The following is a description of a gene set: species: Mus musculus Chemical induction of squamous tumors in the mouse skin induces multiple benign papillomas: high-frequency terminally benign low-risk papillomas and low-frequency high-risk papillomas, the putative precursor lesions to squamous cell carcinoma (SCC). We have compared the gene expression profile of twenty different early low- and high-risk papillomas with normal skin and SCC. Unsupervised clustering of 514 differentially expressed genes (P<0.001) showed that 9/10 high-risk papillomas clustered with SCC, while 1/10 clustered with low-risk papillomas, and this correlated with keratin markers of tumor progression. Prediction analysis for microarrays (PAM) identified genes that distinguished the two papilloma classes, and a majority of these had a similar expression pattern in both high-risk papillomas and SCC. Additional classifier algorithms generated a gene list that correctly classified unknown benign tumors as low- or high-risk concordant with promotion protocol and keratin profiling. Reduced expression of immune function genes characterized the high-risk papillomas and SCC. Immunohistochemistry confirmed reduced T-cell number in high-risk papillomas, suggesting that reduced adaptive immunity defines papillomas that progress to SCC. These results demonstrate that murine premalignant lesions can be segregated into subgroups by gene expression patterns that correlate with risk for malignant conversion, and suggest a paradigm for generating diagnostic biomarkers for human premalignant lesions with unknown individual risk for malignant conversion. from publication Darwiche N, Ryscavage A, Perez-Lorenzo R, Wright L, Bae DS, Hennings H, Yuspa SH, Glick AB (PMID 17525749) Human Gene Set: DARWICHE_PAPILLOMA_RISK_LOW_DN Genes down-regulated during skin tumor progression from low risk papilloma vs normal skin., and this is the list of marker genes: MEOX2, BRSK2, BAG6, TREM2, IRAK1, TNP2, KLF13, RNF26, LYAR, ANP32A, NUF2, MAP2K5, SMIM8, SOD1, PLET1, GSK3B, CLEC3B, PYGO2, SPATA31D1, DIP2A, DENR, NCAN, PUS10, MSI1, SLC39A13, CCT4, ELAPOR1, PLAC8, CDS1, CXCL16, BATF3, SWAP70, TPM3, YTHDF2, TTLL11, COQ8A, RPAIN, RNF19A, APOD, KCNU1, IGHG1, NBN, TEKTIP1, SPP1, MT1F, OGFOD2, RASIP1, PVT1, GRIP1, CITED2, MYO1A, PEPD, DNAJC1, ICAM1, ZNF787, C14orf119, PACSIN2, IFT20, TYRO3, CFAP144, EML4, PTPRJ-AS1, MAN2A2, PHF2, SRSF1, PATJ, GID8, MED17, UBE4B, DCTN1, OTUD1, GNAO1, CCL27, LTBP4, GTF2I, CCT6B, MORN5, BEST1, NPTXR, MEF2C, RAB2B (NCBI Gene Id 84932), FAM3A, FOXL2, ARHGAP4, CRELD1, ACTG2, GKN3P, CDC42EP2, CHP1, BAIAP2, FAM217A, OVOL2, SOX5, ARL2, CD248, TLCD3B, DGUOK, PEX16, ACTA1, QPRT, TMEM144, MRPS18A (NCBI Gene Id 64957), C16orf90, BRF1 (NCBI Gene Id 90137), PPP1R27, POLR1HASP, BCL2A1, MAPK8IP3, GADD45GIP1, TSSK6, KRTAP5-2, AKIRIN2, ANKEF1, TTC9, MYCN, APOE, LYZ, LGMN, SAMHD1, DOK4, SUN1, CPA5, SOD3, SRF, PKHD1, TRBV4-1, TSC22D4, CLVS1, RNF181, CX3CR1, ASNS, GSTZ1, TEX48, GTF2E2, ACTA2, POLI, CHCHD5, RACGAP1, ABHD14B, FAM186A, CALM2, ACSBG1, NIT1, ITPR1, CP (NCBI Gene Id 1356), FBRSL1, VHL, PAQR7, PLA2G10, AMBRA1, BID, RSPO1, PDP2, STRAP, C11orf58, TRMT1, FAM178B, CSPP1, EBF2, ARAP1, KRT2, CTSV, RTRAF, PABPC4, ZNF830, MAP1LC3A, SMU1, NRSN1, RTN4R, CCNI